The following is a description of a gene set: Human Gene Set: GOCC_TRAPPIII_PROTEIN_COMPLEX studied in species Homo sapiens A complex that functions in anterograde transport at the Golgi and also regulates autophagy. In yeast it includes at least the following subunits: Bet3 (as homodimer), Bet5, Trs20, Trs23, Trs31, Trs33, Trs85. TRAPPIII may include further, as yet undescribed, proteins., and this is the list of marker genes: TRAPPC2B, TRAPPC1, TRAPPC6A, TRAPPC3, TRAPPC2, TRAPPC8, TRAPPC12, TRAPPC2L, TRAPPC4, TRAPPC11, TRAPPC5 (NCBI Gene Id 126003), TRAPPC13